The following is a description of a gene set: studied in species Homo sapiens Any process that modulates the frequency, rate or extent of exosomal secretion. Human Gene Set: GOBP_REGULATION_OF_EXOSOMAL_SECRETION, and this is the list of marker genes: SNF8, CHMP2A, HGS, VPS4B, ATP13A2, SMPD3, ATP9A, CHMP3, STAM (signal transducing adaptor molecule), SDC4, PRKN, RAB7A, VPS4A, TSG101, IFNG, SDCBP, SDC1, CHMP6, PDCD6IP